Given this list of marker genes Fabp3, Acadvl, Tcf7l2, Ces1f (carboxylesterase 1F), Htr2b, Igf2, Ces1g, Pcx, Prox1, Nr1h4, Mbtps2, Insig1, Rdh1, Capn2, Rgn, Nr1h3, Sik2, Ifng, Fgf1, Erbb4, Plin5, Abca3, Sirt3, Mfsd2a, Gnai1, Nr1h2, Gpr146, Nr0b1 (nuclear receptor subfamily 0, group B, member 1), Hsd3b9, Adgrf5, Mup4, Apoc2l, Acadl, Ces1b, Apoc3, Bmp5, Ces1d, Igfbp7, Tspo, Dgat2, Hsd3b4, Sirt4, Cyp17a1, Pibf1, Il1a, Aqp8, Mapk1, Armc5, Abcg4, Ormdl3, Slc45a3, Trib3, Mtor, Acsl5, Clcn2, Cyp27b1, Hrh1, Igf1r, Ubr4, Pdk4, Mid1ip1, Srebf2, Brca1, Ceacam2 (NCBI Gene Id 26367), Trex1, Malrd1, Creb1, Gip, Avpr1a, Mlxipl (MLX interacting protein-like), Pla2g4a, Fgf15, Lpcat1, Apoe, Prkg1, Idi2, Tmx1, Sphk2, Lhcgr (NCBI Gene Id 16868), Apob, Fshb, Thrsp, Prkcd, Pde8b, Ces1a, Qki, Mup5, Dab2, Asxl3, Rdh10, Ces1h, Apoc2, Sphk1, Fabp5, Chp1, Kat5, Adora2b, Dgkq, Pla2g3, Serpina12 (serine (or cysteine) peptidase inhibitor, clade A (alpha-1 antiproteinase, antitrypsin), member 12), Mup3, Fdps, Sirt2, Prmt3, Gpld1, Dcaf5, Sf1, Ccn1, Ccdc3, Bmp2, Nr3c1, Erlin2 (NCBI Gene Id 97480), Stard4, Nfkb1, Ces1c, Rest, Pex2, Ormdl2, Cd74, Ggcx, Ogt, Zfp750, Wdtc1, Cga, Gh, Prkaca, Snai1, Obp2a, Akt1, Atg7, Lpcat3, Insig2, Cnep1r1, 3110082I17Rik, Dkkl1, Srebf1, Gper1, Cmtm2a, Atp1a1, Abcd2, Mapk9, Ceacam1, Ppara, Rptor, Nr5a2, Avil, Mup11, Npy1r, Ctdnep1, Igf1, Bglap2, Rab38, Ddx20, Elovl5, Hsd3b5, Erlin1, Dkk3, Htr2c, C3, Egr1, Sirt1, Paqr3, Star, Gfi1, Dhcr7, Rdh9, Scap, Anxa1, Ldlr, Sod1, Abcd1, Ptgs2, Gpam, Akr1c18, Smpd3, Sik1, Abca2, Snai2, Mlst8, Crebl2, Bglap, Hnf4a, Por (NCBI Gene Id 18984), Apoa4 (apolipoprotein A-IV), Slc27a1, Bscl2, Ormdl1, Abcg1, Pck1, Kat2b, Tnf, Ces1e, Lep (NCBI Gene Id 16846), Fgfr4, Bmp6, Ppargc1a, Dgat1 (diacylglycerol O-acyltransferase 1), Sec14l2, Pdgfa, Eif6, Hsd17b13, Pdgfb, Mlx, Htr2a, Pla2g6, Asah1, Rdh16, Rdh16f2, Abhd6 (abhydrolase domain containing 6), Scp2, Nr1d1, Gprc6a, Wnt4, Rdh19, Apoa5, Klhl25, Idh1, Enpp7, Mup2, Dhh, Apoc1, Il1b, Dbi, H6pd, Agt, Cyp7a1, Sorbs1, Paqr4 (NCBI Gene Id 76498), Zbtb20, Samd8 (sterile alpha motif domain containing 8), Avp, Lpgat1, Scarb1, Mup1, Acsl3, Hsd3b8, here is a description of the gene set: studied in species Mus musculus Any process that modulates the frequency, rate or extent of the chemical reactions and pathways resulting in the formation of lipids. Mouse Gene Set: GOBP_REGULATION_OF_LIPID_BIOSYNTHETIC_PROCESS